The following is a description of a gene set: Genes positively differentially expressed in cell type: cDC1 (conventional dendritic cell type 1) upon treatment with cytokine: IL-1α in mouse lymph nodes in vivo. species: Mus musculus Mouse Gene Set: CUI_CDC1_IL1A_RESPONSE_UP from publication Cui A, Huang T, Li S, Ma A, Pérez JL, Sander C, Keskin DB, Wu CJ, Fraenkel E, Hacohen N (PMID 38057668) Cytokines mediate cell-cell communication in the immune system and represent important therapeutic targets. A myriad of studies have highlighted their central role in immune function, yet we lack a global view of the cellular responses of each immune cell type to each cytokine. To address this gap, the authors created the Immune Dictionary, a compendium of single-cell transcriptomic profiles of more than 17 immune cell types in response to each of 86 cytokines (>1,400 cytokine-cell type combinations) in mouse lymph nodes in vivo. A cytokine-centric view of the dictionary revealed that most cytokines induce highly cell-type-specific responses. For example, the inflammatory cytokine interleukin-1β induces distinct gene programmes in almost every cell type. A cell-type-centric view of the dictionary identified more than 66 cytokine-driven cellular polarization states across immune cell types, including previously uncharacterized states such as an interleukin-18-induced polyfunctional natural killer cell state., and this is the list of marker genes: Pttg1ip, AA467197, Napa, Selplg, Gprc5c, Rnf19b, Slc41a2, Ms4a4c, Tspo, Runx3, H2-DMb2, Clic4, Pim1, Pnpla2, Pts, Gramd2a, Armc8, Socs2, Foxn3, Fgr, Malt1, Bbx, Dnase1l3, Bcl2l11, Basp1, Grb2, Cldnd1, Fnbp1l, Enox2, Hap1, Snap23, Ciita, Slfn2, Ifitm3, Coro2a, Man1a, Pdcd4, Nsd3, Cdkn1a, Cst3, Serpina3g, Mt1, Il4ra, Batf3, Btla, Fcgr2b, Spint1, Rab2a, Cxcl9, Jak2, Cpne2 (copine II), Nckap1l, Bcl2a1b, Stat3, Trpv2, Hhex, Glipr2, Cytip, Pik3r1, Cmtm6, Snx8, Baz1a, Ccl17, Scimp, Lmnb1, Rab14, Pik3cg, Jtb, Polr2c, Nampt, Rtf2, Trip12, Lfng, Eif1, Gpcpd1, Tspan13, Fth1, Pfkp, Nrros, Mbd2, Mkrn1, Rara, Sav1, Lyn, Eif6, Rtn4, Dock10, Spred2, Vrk3, Hectd1, Tbc1d8, Jaml, Rab8b, Arhgap26, Atox1, Ifi205, Cflar, Timd4, Wfdc17, Rell1, Ggta1, Zfand3, Tbc1d14, Dpf2, Plgrkt, Cdk2ap2, Arid5a, Ch25h, Sdc4, Ifi207 (interferon activated gene 207), Cd226, Atp6v1b2, Ranbp2, Rabgap1l, Fam241a, Map1lc3b, Atp1a1, Galnt7, Mpc1, Orai1, Fkbp1a, Chmp4b, Socs3, Eif5a, Nlrp3, Sipa1l3, Cd300a, Runx1, St6gal1, Aamp, Cox17, Supt6 (SPT6, histone chaperone and transcription elongation factor), Tsg101, Mif4gd, Cd300lf, Spred1, Xbp1 (X-box binding protein 1), Eif4ebp1, Iscu, Kmo (NCBI Gene Id 98256), Rabep1, Ass1, Clec10a, Oasl2, Cd164, Eif3a, Rras2, Gcnt2, Ldlr, Tle3, Plac8, Stxbp3, Ccnd3, Eva1b, Nr4a3, S100a6, Casp4, Socs1, Plek, Ppa1, Fkbp5, Wnk1, Rnf169, Fh1, Cd274, Il1b, Gatm, Tgfbi (transforming growth factor, beta induced), Ccdc86, Cited2 (Cbp/p300-interacting transactivator, with Glu/Asp-rich carboxy-terminal domain, 2), Sult1a1, Fads1, Ccr7, Pex11a, Slc30a4, Sdhaf1, Gnb4, Rap2a, Pkib, Sri, Sh3pxd2b, Apaf1, Pik3r5, Slc2a1, Slc39a7, Sdhc, Kdm6b, Adam8, Marcks (NCBI Gene Id 17118), Flot1, Dusp5, Ocstamp, Fabp5, Susd6, Ier3, Ptpn1, Ms4a6d, Picalm, Cd80, Crem, P2rx4, Apobec3, Ahr, Serinc3, Igfbp4, Rasa2, Adam19, Adpgk, Sla (src-like adaptor), Adap2, Snd1, H3f3b, Cidea (cell death-inducing DNA fragmentation factor, alpha subunit-like effector A), Lcp2, Srgn, Fyn, Fchsd2, Reep3, Bcl2a1a, Ddx6, Selenos, Trim30a, Litaf, Cd53, Ifitm1, Riok3, Atp6v0a1, Atp1b3, Tmem131l, Cd38, Nfil3, Nup85, Gfra2, Tmem131, Larp1, Tnfrsf13b, Bloc1s6, Slc33a1, Tut7, Mtss1, Tax1bp1, Gpr141, Gpr171, Bhlhe40, Kctd12, Prorsd1, Slfn5, Cd40, Arrdc4, Mllt6, Irf2bp2, Myd88, Rbm47, Fcgr3, Ncoa7, Vdr, Eps8, Enah, Irf5, Pgam1 (NCBI Gene Id 68006), Tab2 (TGF-beta activated kinase 1/MAP3K7 binding protein 2), Plet1 (NCBI Gene Id 76509), B4galt3, Tes, Hpcal1, Il18, Smarce1, Arfgap3, Ccnd2, Cxcl16, Scand1, Ctss, Tmem38b, Syngr2, Etv6, Csf2rb, Gbp5, Slc25a38, Srp9, Lgmn, Laptm4b, Bach1, Lrrk1, Ddit4, Il21r, Gpr146, Adgre5, Cyrib, Clec2d, Csf2rb2, Scd1, Asb2, Hfe, Arl8b, Slc22a15, P2rx5, Stat2, Ctnnd2, Cyp4f16, Uck2, Cish, Ccl22, Txnrd1, Itgae, Atp13a3, Casp6, Swap70, Ffar2, Tm9sf2, Lgals3, Ndrg1, Etv3, Pnp, Klf5, Rab7, Ifitm2, Bcl2a1d, Ly75 (lymphocyte antigen 75), Mcl1, Efhd2, Rab13, Prkcd, Pdcd1lg2, Traf1, Bin2, Ehd1, Mefv, Mrps7, Il10ra, Rnf149, Bcl3, Csad, Lrrc8c, Arhgap22, Chd7, Pacsin2, Htr7, Casp8